The following is a description of a gene set: part of: Metabolism of carbohydrates and carbohydrate derivatives Reactome Pathway: Pentose phosphate pathway studied in species Mus musculus electronically inferred by orthology from the curated human pathway This event has been computationally inferred from an event that has been demonstrated in another species.<p>The inference is based on the homology mapping from PANTHER. Briefly, reactions for which all involved PhysicalEntities (in input, output and catalyst) have a mapped orthologue/paralogue (for complexes at least 75% of components must have a mapping) are inferred to the other species., and this is the list of marker genes: Rbks, Rpia, Pgls, Taldo1, Tkt, G6pdx, Pgm2 (phosphoglucomutase 2), Shpk